The following is a description of a gene set: Human Gene Set: GOBP_CYTOSKELETON_DEPENDENT_CYTOKINESIS studied in species Homo sapiens A cytokinesis that involves the function of a set of proteins that are part of the microfilament or microtubule cytoskeleton., and this is the list of marker genes: SEPTIN5, SEPTIN14, SPAST (NCBI Gene Id 6683), SNX9, CHMP5, KIF4B, SEPTIN3, MYH14, EXOC5, KIF20A, SEPTIN9 (septin 9), IQGAP1, EXOC2, FMN2, RAB11FIP3, SEPTIN7, ARF1, MYH10, RTKN, TTC19, SEPTIN6, RACGAP1, APC (NCBI Gene Id 324), EXOC1, ARL3, DCDC1, RAB35, CHMP4B, CHMP1A, MITD1, SPIRE2, EXOC4, CFL1, ZFYVE19, RHOC, KIF4A, CHMP2B, CENPA, ROCK1, ROCK2, CEP55, MTMR3, CIT, NUP62, BBS4 (Bardet-Biedl syndrome 4), SEPTIN8, PLEC, ARF6, CHMP2A, EXOC6, ORC4, RAB11A, SEPTIN12, ECT2, PLK1, IQGAP2, SHCBP1L, CHMP6 (NCBI Gene Id 79643), KLHDC8B, USP8, SNX18, VPS4A, KIF23, ACTR2, UNC119, ALKBH4, CECR2, SPART, CHMP7, ANKRD53, CUL7, SEPTIN1, BIN3, ZNF365, BIRC5, SPIRE1, SNX33, JTB, SEPTIN2, PDCD6IP, EXOC3, IST1, ROPN1B, CHMP4C, SPTBN1, MTMR4, MAP9, SEPTIN10, ACTR3, CHMP1B, KIF20B, ZFYVE26, WNK1 (WNK lysine deficient protein kinase 1), EFHC1, STAMBP, EXOC6B, WASHC5, ANLN, RASA1, RHOA (ras homolog family member A), NUSAP1, LUZP1, CHMP4A, TRIM36 (NCBI Gene Id 55521), EXOC8, DCTN3, CKAP2, CHMP3, SEPTIN4, ESPL1, NOX5, CHMP4BP1, ANK3, EXOC7, CDCA8, VPS4B, CNTROB, SON, AURKB, LZTS2, IQGAP3, RHOB, SEPTIN11, INCENP, POLDIP2, STMN1